The following is a description of a gene set: species: Homo sapiens Human Gene Set: DR1_Q3 Genes having at least one occurrence of the motif RGGNCAAAGGTCA in the regions spanning 4 kb centered on their transcription starting sites. This matches the NR2F2 transcription factor binding site V$DR1_Q3 (v7.4 TRANSFAC)., and this is the list of marker genes: AP1B1, ARRDC1-AS1, HOXB6, CNTFR, VTA1, BAALC, IGF2BP1, PGF, CALHM1, LAMP2, MRPL11, MOSPD2, NR2F6, OVOL1, INSR, RPRD1B, ZBTB45, NFE2L2, SELENOI, CRABP2, KRTAP15-1, ACOT8, TTYH1, PAPLN, MYH10, GDNF, CSRNP3, DIDO1, ARFGEF2, DCTN1, SLC7A9, BABAM2, CKMT1B, VCL, ASXL1 (ASXL transcriptional regulator 1), EIF4G1, SPSB2, HNF1A, PRDM1, CDX1, HOXD3, CKAP4, F12, ATAT1, NPSR1-AS1, STMN2, PRR14, C2CD2L, MASP2, A1CF, PDZK1, DNMT3A, DUSP3, TNNI1, PDLIM7, MED8, ZSWIM3, SATB1, PRODH2 (proline dehydrogenase 2), SEC22B, DIS3L, TMEM79, SOX5, CLRN3, CDK16, ZBTB40, TLK2, NR4A1, MAP3K11, MOSPD1, HSPD1, BNIP3, IFFO1, RTN4, TMED4, FAM170A, PTH1R, OTUD7B, SPEF1, PAK1IP1, PTCHD4, PARP6, TCN2, AGPS, ATP5PO, PPARGC1A, SLC23A3, UBE2K, GBF1, SMTN, FGFR3, PLEC, DMD, NR2F1, MAP2K3, SMYD5, ADGRA2, GOLGA4, FBLN1 (NCBI Gene Id 2192), SEC16B, ARL6IP1, MLST8, LMOD3, POLR2H, U2AF1L4, ZNF516-DT, CLCNKA, NR2C1, WDPCP, NRAP, SLTM, BOK, UQCR10, PLCD4, SRSF6, SOD1, FGF9, TTI1, AOC2, TOM1L2, MSRB1, GDPD2, BCAM, NFE2L3 (NFE2 like bZIP transcription factor 3), EFNB3, C1orf116, PRMT1, PNPLA2, NEUROG2, DRC3, SCNM1, PTPRG, HIBADH, CCP110, ZNF597, CLIP3, RBMS1, HSD17B8, WBP2NL, ABTB2 (NCBI Gene Id 25841), CUTA, NDUFS1, KIF6, HOXB3, MICAL2, CLDN10, MIR22HG, SPACA6, MTTP, HOXA3, NUDCD1, DCTN2, RAPGEF6, SAMD14, CLDN15, EEF1B2, TIMELESS, SZT2, LRRN1, NR2F2, ZIC4, WDR81, SLC39A5, NPHP4, ARHGEF7, NET1, LMX1B, NR4A3, PAN2, DPF3, EFEMP1, INHBC (NCBI Gene Id 3626), CCL15, PSMF1, WRAP53, PIPOX, SS18, FAM20C, SLC25A1, LMO3, PRRX2, HSPE1, REST, RBBP6, NHERF4, ZFHX3, SHF, PLA2G2F, MREG, SLC25A51, BLTP3A, BIN3, BPIFA2, EMG1 (NCBI Gene Id 619532), PRR7, SYT4, LRP1, PHB2, UBE2R2, HS6ST2, CNOT9, GTF3C2, DNAJA2, PAX7, CSF2, GRPEL1, ID1, DCHS1, CLCN2, SLC25A35, MARK2, KCNE5, ERBB2, PCDH7 (protocadherin 7), TREX1, MAP3K20, SMG5, HMGCS2, WFIKKN2, USP37, CDIN1, CALM1, USP12, PLPPR1, SLC7A7, ADAMTS19, PRDM16 (PR/SET domain 16), HOXC13, C14orf132, SHFL, TP53, NCDN, RASAL1, ATN1, PAK4, FKBP5, SELENOM (NCBI Gene Id 140606), PPTC7, TRPT1, KCNK10, CTAG2, PFN1, ZBTB12, NUDT22, TTYH2, PCBP4, YPEL3, LYSMD1, CBLN4, STOML2, CELF3, YBX2, TOMM70, RBKS, ESRRA, POU5F1, RTP3, PPP1R14D, SNAP25, LGI4, FANCB, NEDD9, SSH2, C3orf18